Given this list of marker genes MAPK1, PDE2A, CEP290, IQCB1, IFT140, MYT1L, ZEB2, AFF3, CAMK2B, ITPR1, RPGRIP1, PCYT1A, DPAGT1, DYRK1A, AHDC1, SPATA7, PUS7, LCA5, KAT5, NMNAT1, GLYCTK, CACNA1B, SPTBN1, TAOK1, GRIK2, HTT (huntingtin), MECP2, PGAP3, MBD5, DHX30, TPR, IMPDH1, HNRNPK, AIPL1, TUBB4B (tubulin beta 4B class IVb), UBE3A, KIF15, H4C5, ZFX, PTRHD1, ADNP, ANK3, RERE, ZBTB18, CACNA2D1, PIGF, CDKL5, EEF1A2, OCA2, NTNG2, LRAT (NCBI Gene Id 9227), CERT1, RNU4-2, GRIN1, GNB2 (NCBI Gene Id 96628), NEXMIF, VPS13A, SMC1A, CRELD1, SNRPN, BRAF, GABBR2, GDF6, RHOBTB2, ATG7, RPE65, CRB1, KCNJ13, CRX, FOXG1, GUCY2D, DDC, RAI1, TRAPPC9, USP45, SVBP, NTNG1, RDH12, TULP1, ZSWIM6, EIF4A2, SHANK3, RD3, here is a description of the gene set: Abnormal movements of face and head. studied in species Homo sapiens Human Gene Set: HP_STEREOTYPIC_MOVEMENTS_OF_FACE_AND_HEAD Stereotypic movements of face and head